The following is a description of a gene set: A reduction in the amount of adipose tissue (fat) compared with the amount previously present in an individual. Adipose tissue loss studied in species Homo sapiens Human Gene Set: HP_ADIPOSE_TISSUE_LOSS, and this is the list of marker genes: ERCC6, LMNB2, RNF113A, ERCC4, AARS1, GTF2E2, CARS1, PRIM1, LIPE, CAV1, ERCC8, ERCC2, ZMPSTE24, GTF2H5, INSR (NCBI Gene Id 3643), BLM, MPLKIP, CIDEC (cell death inducing DFFA like effector c), BSCL2, PPARG, FOS, PIK3R1, AGPAT2, TARS1, LMNA, PCYT1A, CAVIN1, POLD1, PSMB8, KCNJ6, PLIN1, ERCC3, POLR3A, FBN1